The following is a description of a gene set: species: Mus musculus Mouse Gene Set: GOBP_PROTEIN_LOCALIZATION_TO_CYTOPLASMIC_STRESS_GRANULE A process in which a protein is transported to, or maintained in, a location within a cytoplasmic stress granule., and this is the list of marker genes: Ssb (NCBI Gene Id 228007), Ddx1, Dhx9, D1Pas1, Pak1, Tia1 (NCBI Gene Id 67108), Ddx3x, Dcp1a, Ybx1